The following is a description of a gene set: studied in species Homo sapiens Human Gene Set: GOMF_TAT_PROTEIN_BINDING Binding to Tat, a viral transactivating regulatory protein from the human immunodeficiency virus, or the equivalent protein from another virus., and this is the list of marker genes: SMARCB1, SMARCA4, ACTB, DLL1, TRIM32, GABARAPL1, NPM1, CTDP1, DNAJA1, MDFIC